Given this list of marker genes PIGL, GPC6, PIGW, MCTP2, PRIM1, FANCM, EBP, KMT2D, SMC5, FKBP6, ALDH1A3, ATP6V1A, DGCR6, BPTF, FBXO28, PCGF2, SPTBN1, FANCF, DDB1, BCR, BAZ1B, RBM10, FANCB (NCBI Gene Id 2187), GPKOW, HNRNPH2, DNAJC30 (DnaJ heat shock protein family (Hsp40) member C30), TXNL4A, STX1A, CAMK2G, CRKL, FOXL2, SEPTIN9, LIMK1, BRPF1, KAT6B, FBXL4, MED13, ALG14, LIFR, MEG3, ARX, RAD51C, ESS2, RAB18, MYH3, WARS1, FANCI, ACTG1, MOGS (NCBI Gene Id 7841), FANCG, CUL4B, PIGV, MYCN, POLR3A, HSPG2, CTCF, HNRNPH1, PIGA, FANCA, NCF1, FRA10AC1, BRIP1, RNU4ATAC, MYL11, PCLO, DONSON, DLK1 (delta like non-canonical Notch ligand 1), KIF15 (kinesin family member 15), MAP2K2, ERCC1, EP300, RAD51, PCNT, ADAMTSL2, KCNJ2, TLK2, GTF2I, PRMT7, DGCR2, SOX6, PIK3CA, STRA6, H4C5 (H4 clustered histone 5), ZNF148, MAPK1, MECP2, MADD, BRAF, HUWE1, ZFX, RNU4-2, ARID2, ERMARD, TBL2, SOX9, FANCE, SNX14, B3GLCT, UGDH, DVL3, AHDC1, NSUN2, FOXG1, SMPD4, RPL10, METTL27, GNB2, KCNJ5, ZMYM2, IPO8, EIF4A2, FANCD2 (FA complementation group D2), INPPL1, GJA1, ZBTB18, PAX3, LMNB1, KMT2A, TENM3, DNMT3A, TBX15, LIG4, CDC42BPB, MAFB, SIN3A, ELN, RIPK4, SF3B2, CLTCL1, EIF5A, FANCC, KDM4B, SRCAP, BBS2, MAGEL2, TUBB, KANSL1, UBE2T, SETD5, ODC1, HDAC4, MLXIPL, GTF2IRD1, TRIP12, PIGO, SLC2A10, FTSJ1, THOC6, RFX7, CLIP2, HNRNPK, RERE, LARP7, FOXP2, ALX4 (NCBI Gene Id 64068), BUB1, EDEM3, PPP1R12A, PIK3R2, ROR2, GTF2IRD2, PGM3, MAD2L2, LMNA, BMP1, PIGY, CEP55, PGAP2, DGCR8, FIBP, SOX11, ANK1, XRCC2, PHF6, BCL11B, IRX5, DACT1, MUSK, TRMT1, SLX4, MASP1, GJA8, INTS1, BRCA2, TBL1XR1, COLEC10, TAF4, PRR12, DVL1, POLA1, CLP1, TBX1, USP9X, TGFB3, SALL1, NFIB, SPEN, SCARF2, GJA5, KPTN, B9D2, CHN1, EIF4H, HHAT, BRCA1, UBAP2L, VPS37D, SMOC1, ADNP, SETBP1, KIF26A, NEUROG1, PUF60, ACTB, WAC, RHOA, BCOR, PIEZO2, DHX9, PURA, FBXO11, ATP6V1E1, ANKRD11, PDE4D, AUTS2, SMAD4, CUX1, CEP57, AP3B2, TRAF7, MAP2K1, RAC1, COLEC11, FANCL, MAPRE2, DOCK6, ERCC4, NXN, FZD2, EFEMP2 (NCBI Gene Id 30008), WDR35, SPOP, RAP1B (RAP1B, member of RAS oncogene family), COG7, PYCR1, DDX3X, CEP152, KRAS, RFC2, RECQL4, WNT5A, STAC3, BICRA, POLR1A, SLC6A17 (NCBI Gene Id 388662), KDM6A, LMBRD2, CHD4, OTUD6B, KCTD1, SETD2, MAPK8IP3 (mitogen-activated protein kinase 8 interacting protein 3), TP63, DDR2, PRKAR1B (NCBI Gene Id 645590), CACNA1G, ORC1, MED12, ERCC6, UBE3B (ubiquitin protein ligase E3B), MAPKAPK5, RBMX, RTL1, ATR, FAT4, PGAP3, SALL4, SMO, STT3A, ZMPSTE24, EXOSC2, AFF3, FOXP1, DDX6, RBPJ, NUAK2, CRELD1, SLC25A24, GATAD2B, PALB2, TMEM270, TBC1D2B, DNM1, GABRA3 (NCBI Gene Id 2556), SMARCA2, CDK13 (NCBI Gene Id 8621), HNRNPR, RFWD3, DCHS1, CCNK, DPH5, TMEM107, BUD23, CREBBP, DRG1, here is a description of the gene set: An abnormal size of the palpebral fissures for example unusually long or short palpebral fissures. Abnormal size of the palpebral fissures Human Gene Set: HP_ABNORMAL_SIZE_OF_THE_PALPEBRAL_FISSURES species: Homo sapiens